Given this list of marker genes FAM78B, COL11A2, RHBDL2, ENTPD3, PHEX, RUNX2, DLX3, WNT4, BMP2, PHOSPHO1, COL13A1, USHBP1, HEYL, TBX2, MMP9, TNC, IBSP, CLDN5, DLX5, BMP3, DLX6, IFITM5, PTH1R, JCHAIN, CRYGN, LRP5, GGT5, BMX, SPARC, NOTCH3, WDR86, SLC36A2, MEF2C, SATB2, SPP1, COL1A1, CDH15, MEPE, BMP5, MMP13, INSC, LRP4, SP7, HES1, SOST (NCBI Gene Id 8149), PRSS35, ACP5, COL22A1, DKK1, DNASE1L3, ALPL (alkaline phosphatase, biomineralization associated), GPIHBP1, BGLAP, SLC13A5, BMP8B, EGR1, DLL4, LOX, DMP1, A2M, here is a description of the gene set: Human Gene Set: THALER_BONE60 species: Homo sapiens To further normalize for possible batch effects between the samples, RUVSeq was applied in conjunction with DESeq2. Bone tissue-related gene-sets as defined by DESeq2 and including already well-known bone related genes, were then compared between human and mouse and only genes found in both organisms were selected for the final gene-sets. from publication Thaler R, Khani F, Sturmlechner I, Dehghani SS, Denbeigh JM, Zhou X, Pichurin O, Dudakovic A, Jerez SS, Zhong J, Lee JH, Natarajan R, Kalajzic I, Jiang YH, Deyle DR, Paschalis EP, Misof BM, Ordog T, van Wijnen AJ (PMID 36202795) Genes selectively higher expressed in human and mouse bone tissue compared to a series of other muskuloskeltal and non muskuloskeletal human and mouse tissues